The following is a description of a gene set: The chemical reactions and pathways resulting in the formation of dicarboxylic acids, any organic acid containing two carboxyl (-COOH) groups. Mouse Gene Set: GOBP_DICARBOXYLIC_ACID_BIOSYNTHETIC_PROCESS studied in species Mus musculus, and this is the list of marker genes: Reg3g, Kynu, Xiap, Got1, Kmo, Extl3, Htt, Gls, Acmsd (amino carboxymuconate semialdehyde decarboxylase), Mthfd1l, Gls2, E2f1, Got2 (glutamatic-oxaloacetic transaminase 2, mitochondrial), Ido1, Slc25a12, Rac1, Bin1, Got1l1, Bcl10, Mthfd1, Haao